Given this list of marker genes TAF9B, AGO4, PPP1R21, HMG20A, CDK5RAP2, SIK3, MBD6, DCK, CPT1A, ASAH2, ENTPD1, EPC2, CMAS (cytidine monophosphate N-acetylneuraminic acid synthetase), KRIT1, UBALD2, BRD9, ZNF703, RBBP4, RP9, DLGAP4, ATAD2B, TGFBR2, CAV2, EVI5L, CALCOCO1, BLTP1, ZNF597, CLEC4F, BIRC2, HOOK3, NCK2, TRIM63, RAB3GAP1, HEYL, ABI1, FHOD3, CLIC1 (chloride intracellular channel 1), PCGF3 (NCBI Gene Id 253443), LTK, CNOT6, RPS6KA5, FGD3, RPS19, CCDC125, INPP5K, PRMT9, CAMTA1, SNX33, ST3GAL6, SUPT20H, PAM16, PSKH1, BTBD8, ACTN1, FTX, UNKL, NFATC1 (NCBI Gene Id 4772), CROT, PRRC2B, RELCH, AFF3, SUSD5, TNFRSF19, SPSB2, GFRA2, ZW10, HDAC9, CCDC32, G2E3, MARF1, SLC12A3, LACTB, DNAJC21, CYTH1, UVSSA, NCAPD2, RNF19A, HIPK3, CCNG2, STK38L, CCDC82, STX17, SPTBN1, CALCRL, MEF2A, PRR11, TSPYL4, TTC39B, ANKRD6, IPMK, SERP1, MCTP2, TRAF6, COX20, TBC1D8B (NCBI Gene Id 54885), PPP1CC, S1PR1, C2orf68, NNT, CNST, FICD, BCLAF3, LMO4, ZBTB1, PHKA2, GDAP2, SETX, SPO11, TMEM98, ZFAND6, DCAF5, PLGRKT, ARHGDIB, ZNF655, COG1, HBP1, RASA2, JMJD1C, RENBP, VPREB1, KLHL6, CAMK1G, AK3, CEP89, THBD, TCTA, HIVEP2, ADNP, CHMP1B, CHST1, GANC, ANKRD16, DLG1, EVI2A, ATG16L2, NCOA2, GSKIP, VBP1, CYLD (NCBI Gene Id 8010), MINDY2, FAM76B (NCBI Gene Id 143684), LPAR6, CENPN, LASP1, CDK17, ARHGAP15, NSD3, FNIP1, ANAPC13, BLOC1S1, MKNK2, SPRR2A, MAF1, SDHAF2, ARPC5, CSGALNACT1, CDIP1, HP1BP3, RRM2B, IRS2, MAP3K1, CBFB, CD1D, RSPH1, PAIP2, NDE1, RTF1, TMC7, WBP1, DYNLT1, GPR19, CACNA1B, PIK3IP1, ESR1, MMP11, COL5A3, ELMOD2, RPL18A, OTUD1, YWHAB, PIPOX, MECP2, SECISBP2L, UBE2J1, PNISR, FAHD2A, CENPE, CKAP2 (NCBI Gene Id 55221), ZNF260, PPP1R13B, AKAP9, LEF1, MSH3, CKAP2L, CERS5, TAX1BP1, NCAPD3, STAG3, DENND1B, VGLL4, here is a description of the gene set: from publication Croker BA, Krebs DL, Zhang JG, Wormald S, Willson TA, Stanley EG, Robb L, Greenhalgh CJ, Förster I, Clausen BE, Nicola NA, Metcalf D, Hilton DJ, Roberts AW, Alexander WS (PMID 12754505) studied in species Homo sapiens Human Gene Set: GSE369_SOCS3_KO_VS_WT_LIVER_DN Changes in mouse liver mRNA profiles following intraperitoneal cytokine injection. Either interferon-gamma-/-, albumin-cre(-) Socs3(w/fl) mice, or albumin-cre(+) Socs3(-/fl) mice were injected with either phosphate-buffered saline, interferon-gamma, or interfeukin-6, and livers taken after 4h. Genes down-regulated in livers: SOCS3 knockout versus wildtype.